Given this list of marker genes BVES, MSC, GATA4, NPPB, SMAD1, BMP4, NPPA, SMAD5, GJB6, ID2, BMPR1A, HEY2 (NCBI Gene Id 30830), GJA1, HOPX, MESP1, TBX3, GJA5, TBX5, NOTCH1, GATA6, IRX3, SMAD4, MAML1, CDC42, DSG2, SCN5A, ISL1, CACNA1G, HEY1, NKX2-5, NOTCH2, MSX1 (msh homeobox 1), KCNJ8, MSX2, SHOX2, HCN4, TBX18, here is a description of the gene set: The process whose specific outcome is the progression of the cardiac conduction system over time, from its formation to the mature structure. The cardiac conduction system consists of specialized cardiomyocytes that regulate the frequency of heart beat. Human Gene Set: GOBP_CARDIAC_CONDUCTION_SYSTEM_DEVELOPMENT studied in species Homo sapiens